Given this list of marker genes GSTP1, GGT5, IMPDH2, CYP3A4, PNP, ACY1, GMPS, NT5C2, SLCO1B1, UGT3A2, SLC29A2, UGT2A3, UGT2B4, UGT2A1, TPMT, CES1, ABCC4, PON3, VAV1, GLYATL2, ABCC1, SULT1E1, BCHE, SERPINA6, PON1, UGT2B28, UGT1A8, SLCO1B3, UGT1A7 (UDP glucuronosyltransferase family 1 member A7), UGT2B7, IMPDH1, UGT3A1, ACSM2B, SLC29A3, CYP2E1, NAT2, UGT1A6, SLC28A2, XDH, CES2, ITPA, GSTA1, NME2, RAC1, ADH1A, PCK1, ADK, CYP2C9, GLYATL1, NUDT15, NAT1, ABCC3, GGT6, ACSM4, SLC22A3, NME1, ACSM2A, ALB, GUK1, UGT2A2 (UDP glucuronosyltransferase family 2 member A2), CYP2D6, GSTM1, HPRT1, BSG, VAV3, CYP2C19, SULT1A3, MAPDA, SLCO1A2, UGT1A1, UGT1A5, GGT7, SLC22A8, ABCC5, UGT2B10, UGT2B11, AKR1C1, ABCC2 (NCBI Gene Id 1244), SLC22A1, HSD11B1, SULT2A1, VAV2, GLYATL3, CNDP2, UGT1A4, ADA, ABCG2, SULT1A1, UGT2B15, UGT1A3, UGT2B17, SLC16A1, GLYAT, ACSM5, SLC22A7, GSTT1, SULT1A4, CYP2C8, GSTA2, SLCO2B1, HSD11B2, SLC28A3, SULT1C4, UGT1A10, SLC29A1, UGT1A9, GGT1, ABCB1, SLC22A2, here is a description of the gene set: Drug ADME Human Gene Set: REACTOME_DRUG_ADME species: Homo sapiens